Given this list of marker genes TCF20, CYP2C9, MYO1F, PTGIS, COL10A1, MVK, TRAPPC10, ONECUT1, CD83, B4GALT1, AKAP9, TNXA, ACTB, DDX18, STX16, CSNK2A2, PTHLH, MPP2, ITGB3, TRIP13, PTPRU, MC4R, SET, GUCY1A2, LTBP2, RBM34, FSHR, SGCB, CHRM5, ARCN1, STX1A, CHMP1A (NCBI Gene Id 5642), ELF2, KAT2A, CBLB, PFKFB3-AS1, MAPK8, SERPINA3, GRN, CYP2A6, GRP, PSG7, CDH4, RALB, MT1B, CRHR2, HRK, GZMA, IL18, ARHGAP4, OR1E1, PTGFR, ELANE, CBS, GNB3, FBN2, CNP, INPP5A, RNF113A, RELN, NMU, ELAVL2, SALL2, GFUS, CEACAM4, PRSS3, CD40LG, TRAIP, SLC2A4, FAH, SCARF1, FUT8, RPL36A, VPS72, CALCR, SLC5A2, UGT2B7, MAMLD1, CYP2B6, ASPH, AOX1, MPV17, HSPA1A, JAK1, SH3GL3, ELK1, GP5, FRZB, SPRR2A, CDKN1A, GHRHR, TACR2, RTN1, PLXNB1, PENK, IER2, TFAP2A, G3BP1, ADORA2A, KHSRP, STX4 (syntaxin 4), EZR, AP2B1, KCNMA1, NPR2, VSNL1, HBE1, MT1F, NR4A3, EOLA1-DT, DLG3, GDF5, PDE3B, KLHDC3, TRIM26, EXOC5, RBMX, LTC4S, WNT2, RELA, FAM30A, SELP, KRT1, EYA2, RFX5, FOXJ1, ETV3, HYOU1, SGCG, GATA1, CALCRL, RB1, MMP8, MEP1B, HCLS1, ANGPT1, BTN2A1, FAM53B, HMMR (NCBI Gene Id 3161), GLUD1, EPHB3, CHRNG, PCDHB11, TPD52 (NCBI Gene Id 7163), KIF20B, SLC6A2, BRD2, CXCL5, CA1, SERPINE1, CALB2, TSHB, ACVR2A, IGHM, UBL5P4, USF1, PPP1R7, H1-10, MEN1, RBL1, SLC30A3, PPP3CB (NCBI Gene Id 5532), TIMM17A, MYH1, PRKAR2B, TRHR, LIFR, PSMF1, SLC39A9, FGFR2 (fibroblast growth factor receptor 2), CCL2, HRG, FGG, TRA2A, AIF1, C4BPA, FGF6, POLR1HASP, CD3D, MYL2, INHBA, MAST1, CCNO (NCBI Gene Id 9998), TRGC1, AR, EIF2S3, EOLA1, EIF2AK2, ZKSCAN3, SQLE, ENPEP, PDE4B, MLC1, POP1, CXCR2, PDLIM1, UBC, PIK3R4, DDR2, SLC1A1, PCDHB17P, ATN1, MDC1, UQCRB, NRG1, GLRA2, ARHGAP1, HBZ, DPYD, HNRNPH2, HTN3, ASNS, TBR1 (NCBI Gene Id 94313), GCNT2 (glucosaminyl (N-acetyl) transferase 2 (I blood group)), HSPG2, ADRA1A, EFNB3, CHIC1, PROC, LTK, ADRB3, EPCAM, CUX1, MADD, TNPO1, FOXO1, MAGEA3, RAB33A, PTPRN2, MAGEA5P, SCG2, MLLT10, SMARCA1, RUBCN, STXBP3, GLA, ZNF8, CSF1, AMD1, NCAM1, ATP6V0A1, FOXF2, here is a description of the gene set: studied in species Homo sapiens Human Gene Set: KAYO_AGING_MUSCLE_UP from publication Kayo T, Allison DB, Weindruch R, Prolla TA (PMID 11309484) Upregulated in the vastus lateralis muscle of aged vs young adult rhesus monkeys In laboratory rodents, caloric restriction (CR) retards several age-dependent physiological and biochemical changes in skeletal muscle, including increased steady-state levels of oxidative damage to lipids, DNA, and proteins. We have previously used high-density oligonucleotide arrays to show that CR can prevent or delay most of the major age-related transcriptional alterations in the gastrocnemius muscle of C57BL/6 mice. Here we report the effects of aging and adult-onset CR on the gene expression profile of genes in the vastus lateralis muscle from rhesus monkeys. Gene expression analysis of aged rhesus monkeys (mean age of 26 years) was compared with that of young animals (mean age of 8 years). Aging resulted in a selective up-regulation of transcripts involved in inflammation and oxidative stress, and a down-regulation of genes involved in mitochondrial electron transport and oxidative phosphorylation. Middle-aged monkeys (mean age of 20 years) subjected to CR since early adulthood (mean age of 11 years) were studied to determine the gene expression profile induced by CR. CR resulted in an up-regulation of cytoskeletal protein-encoding genes, and also a decrease in the expression of genes involved in mitochondrial bioenergetics. Surprisingly, we did not observe any evidence for an inhibitory effect of adult-onset CR on age-related changes in gene expression. These results indicate that the induction of an oxidative stress-induced transcriptional response may be a common feature of aging in skeletal muscle of rodents and primates, but the extent to which CR modifies these responses may be species-specific.